Given this list of marker genes PRKAG2, PPP2R1B, PRKAA2, ADCY6, ADRA2C (adrenoceptor alpha 2C), PKLR, GNAS, ADCY3, KCNB1, CACNA1E, AGPAT1, GNAI1, STK11, GNG3, RAPGEF3, CACNA1C, PLCB2 (phospholipase C beta 2), SLC2A1, FFAR1, GCGR, GNB4, PFKFB1, ABCC8, PRKACB, CD36, PRKAB2, ADCY4, CACNA1A, ITPR1, PPP2CB (protein phosphatase 2 catalytic subunit beta), ACACA, ITPR2, ACSL3, CHRM3, PLCB1, GNGT2, GNB5, FASN, GNG5, RAPGEF4, ADIPOR1, GNAI2, ADCY2, PLCB3, ADCY7, KCNC2, GNB1, SLC2A2, CACNB3, INS, GNG4, IQGAP1, GNA11, CACNA2D2, RAP1A, GNAQ (NCBI Gene Id 2776), GNB3, ITPR3, STX1A, ADIPOQ, ACSL4, ADIPOR2, ACLY, GLP1R, KCNG2, ADCY5, PRKCA, MLXIPL, GNA14, GNG8, PPP2R5D, GNG13, GNG10, VAMP2, GNGT1, PRKAR2A, KCNS3, AHCYL1, MLX, PRKACA, PRKAR2B, GNA15, ADCY1 (NCBI Gene Id 449484), PRKAR1B, GNG7, CACNA1D, SYT5, ADCY8, MARCKS, TALDO1, KCNJ11, PPP2CA, PPP2R1A, SNAP25, CACNB2 (calcium voltage-gated channel auxiliary subunit beta 2), GNG11, ACACB, PRKAR1A, PRKACG, GCG, TKT, STXBP1 (NCBI Gene Id 6812), ADRA2A, AKAP5 (NCBI Gene Id 9495), GNG12, ADCY9, GNG2, GNB2, here is a description of the gene set: Reactome Pathway: Integration of energy metabolism Many hormones that affect individual physiological processes including the regulation of appetite, absorption, transport, and oxidation of foodstuffs influence energy metabolism pathways. While <b>insulin</b> mediates the storage of excess nutrients, <b>glucagon</b> is involved in the mobilization of energy resources in response to low blood glucose levels, principally by stimulating hepatic glucose output. Small doses of glucagon are sufficient to induce significant glucose elevations. These hormone-driven regulatory pathways enable the body to sense and respond to changed amounts of nutrients in the blood and demands for energy.<br>Glucagon and Insulin act through various metabolites and enzymes that target specific steps in metabolic pathways for sugar and fatty acids. The processes responsible for the long-term control of fat synthesis and short-term control of glycolysis by key metabolic products and enzymes are annotated in this module as seven specific pathways:<br><b>Pathway 1. Regulation of insulin secretion.</b><br><b>Pathway 2. Glucagon signalling in metabolic pathways:</b> In response to low blood glucose, pancreatic alpha-cells release glucagon. The binding of glucagon to its receptor results in increased cAMP synthesis, and Protein Kinase A (PKA) activation.<br><b>Pathway 3. PKA mediated phosphorylation:</b>PKA phosphorylates key enzymes, e.g., 6-Phosphofructo-2-kinase /Fructose-2,6-bisphosphatase (PF2K-Pase) at serine 36, and regulatory proteins, e.g., Carbohydrate Response Element Binding Protein (ChREBP) at serine 196 and threonine 666.<br>In brief, the binding of insulin to its receptor leads to increased protein phosphatase activity and to hydrolysis of cAMP by cAMP phosphodiesterase. These events counteract the regulatory effects of glucagon.<br><b>Pathway 4: Insulin stimulates increased synthesis of Xylulose-5-phosphate (Xy-5-P)</b>. Activation of the insulin receptor results indirectly in increased Xy-5-P synthesis from Glyceraldehyde-3-phosphate and Fructose-6-phosphate. Xy-5-P, a metabolite of the pentose phosphate pathway, stimulates protein phosphatase PP2A.<br><b>Pathway 5: AMP Kinase (AMPK) mediated response to high AMP:ATP ratio:</b> In response to diet with high fat content or low energy levels, the cytosolic AMP:ATP ratio is increased. AMP triggers a complicated cascade of events. In this module we have annotated only the phosphorylation of ChREBP by AMPK at serine 568, which inactivates this transcription factor.<br><b>Pathway 6: Dephosphorylation of key metabolic factors by PP2A: </b>Xy-5-P activated PP2A efficiently dephosphorylates phosphorylated PF2K-Pase resulting in the higher output of F-2,6-P2 that enhances PFK activity in the glycolytic pathway. PP2A also dephosphorylates (and thus activates) cytosolic and nuclear ChREBP.<br><b>Pathway 7: Transcriptional activation of metabolic genes by ChREBP:</b> Dephosphorylated ChREBP activates the transcription of genes involved in glucose metabolism such as pyruvate kinase, and lipogenic genes such as acetyl-CoA carboxylase, fatty acid synthetase, acyl CoA synthase and glycerol phosphate acyl transferase. studied in species Homo sapiens part of: Metabolism